The following is a description of a gene set: The directed movement of neutral amino acids, amino acids with no net charge, into, out of or within a cell, or between cells, by means of some agent such as a transporter or pore. studied in species Mus musculus Mouse Gene Set: GOBP_NEUTRAL_AMINO_ACID_TRANSPORT, and this is the list of marker genes: Slc43a2, Slc36a3, Slc7a13, Sfxn2, Slc1a5, Slc7a5, Nfe2l1, Slc1a4, Slc43a1, Rgs2, Cltrn (collectrin, amino acid transport regulator), Slc6a19, Sfxn3, Slc7a11, Slc7a10, Slc36a4, Slc6a5, Slc3a2, Slc25a38, Ace2, Lep, Slc38a6, Slc6a9, Slc6a6, Slc1a1, Slc38a7 (solute carrier family 38, member 7), Slc38a2, Slc7a7, Slc6a15, Slc25a12, Slc6a20b, Slc6a14, Slc36a1, Slc32a1, Slc6a18, Slc38a1, Mfsd12, Slc7a8, Llgl2, Slc7a6, Slc38a3 (NCBI Gene Id 76257), Slc3a1, Rgs4, Sfxn1, Slc6a17, Slc6a20a, Slc1a2, Slc7a9 (solute carrier family 7 (cationic amino acid transporter, y+ system), member 9), Slc38a9, Slc36a2, Slc38a4, Slc6a7, Slc38a5, Nfkbie, Ctns, Slc25a13